Given this list of marker genes Smarcb1, Pih1d1, Smarca4, Ager, Mlxipl, Usf2, Foxa2, Adcy8, Pdx1, Gck, Usf1, here is a description of the gene set: The series of molecular signals mediated by the detection of carbohydrate. Mouse Gene Set: GOBP_CARBOHYDRATE_MEDIATED_SIGNALING species: Mus musculus